The following is a description of a gene set: studied in species Mus musculus Mouse Gene Set: GOBP_EOSINOPHIL_MIGRATION The movement of an eosinophil within or between different tissues and organs of the body., and this is the list of marker genes: Ccl11, Ccl25, Ccl1, Il4, Ccl8, Cd300a, Ccl22, Ccr3, Scg2, Ccl21a, Ccl7, Ccl5, Ccl2, Ccl21b, Ccl3, Epx, Dapk2, Ccl19, Ccl12, Adam8, Ccl26, Ptger4, Ccl24, Cx3cl1, Lgals3, Ccl4